The following is a description of a gene set: Human Gene Set: HP_LOBULATED_TONGUE Lobulated tongue studied in species Homo sapiens Multiple indentations and/or elevations on the edge and/or surface of the tongue producing an irregular surface contour., and this is the list of marker genes: DDX59 (DEAD-box helicase 59), TOPORS, OFD1, MKS1, C2CD3, FAM149B1, TMEM231, PDE6D, RAB34, MEF2C, KIF7, TMEM216, NEK1, SCNM1, TCTN3, KIAA0753, CEP120, CPLANE1 (ciliogenesis and planar polarity effector complex subunit 1)